Given this list of marker genes UGCG, B4GALNT1, A3GALT2, B4GALT6, B4GALT3, UGT8, B3GALT2, NEU4, ST3GAL5, B3GALT1, GALC, B3GNT5, GBA1, B4GALT4, A4GALT, GAL3ST1, NEU3, ARSA, B4GALT5, GBA2, GLA, here is a description of the gene set: Human Gene Set: WP_GLYCOSPHINGOLIPID_METABOLISM studied in species Homo sapiens Glycosphingolipid metabolism